The following is a description of a gene set: species: Homo sapiens Human beta-1,3-glucosyltransferase like protein (B3GALTL, HGNC Approved Gene Symbol: B3GLCT; MIM:610308; CAZy family GT31), localised on the ER membrane, glucosylates O-fucosylated proteins. The resultant glc-beta-1,3-fuc disaccharide modification on thrombospondin type 1 repeat (TSR1) domain-containing proteins is thought to assist in the secretion of many of these proteins from the ER lumen, and mediate an ER quality-control mechanism of folded TSRs. Defects in B3GALTL can cause Peters plus syndrome (PpS; MIM:261540), an autosomal recessive disorder characterised by anterior eye chamber defects, short stature, delay in growth and mental developmental and cleft lip and/or palate (Heinonen & Maki 2009). Reactome Pathway: Defective B3GALTL causes PpS part of: Diseases associated with O-glycosylation of proteins, and this is the list of marker genes: ADAMTS1, ADAMTS14, THSD7A, ADAMTSL2, THBS2, ADAMTS6, ADAMTS13, ADAMTS10, CFP, ADAMTS3, THSD7B, ADAMTSL5, ADAMTS15, THSD4, SBSPON, SEMA5A, ADAMTS18, SPON1, THSD1, SPON2, ADAMTS20, B3GLCT, ADAMTS16, THBS1, ADAMTS4, ADAMTS9 (ADAM metallopeptidase with thrombospondin type 1 motif 9), ADAMTSL1, ADAMTS17, SSPOP, ADAMTS7, SEMA5B, ADAMTS19, ADAMTS12, ADAMTS5, ADAMTS2, ADAMTSL4, ADAMTS8, ADAMTSL3